Given this list of marker genes RRN3P2 (RRN3 pseudogene 2), SMYD3, GTF2B, SCAF8, ERBB2 (erb-b2 receptor tyrosine kinase 2), MAF1, UVSSA, ESRRB, PCF11, RTRAF, RRN3, NCOA3, RPAP2, WDR43, WAC, DHX9, RPRD1A, RPRD1B, RECQL5, CTR9, SCAF1, SCAF4, POLR2M, AGO2, SPTY2D1, SUPT4H1, ELP2, PCIF1 (NCBI Gene Id 63935), SMYD2, LEO1, PAF1, CDC73, BRD4, URI1, RPRD2, ELOF1, CCAR2 (NCBI Gene Id 57805), AGO1, ERCC5, HNRNPU, ZNF326, here is a description of the gene set: Human Gene Set: GOMF_RNA_POLYMERASE_CORE_ENZYME_BINDING species: Homo sapiens Binding to an RNA polymerase core enzyme, containing a specific subunit composition defined as the core enzyme.